The following is a description of a gene set: The synchronization of a circadian rhythm to environmental time cues such as light. studied in species Mus musculus Mouse Gene Set: GOBP_ENTRAINMENT_OF_CIRCADIAN_CLOCK, and this is the list of marker genes: Rbm4, Opn5, Sik1, Rbm4b, Pde6b, Sox14, Trp53, Atoh7, Mta1, Pml, Ppp1cc, Usp2, Cry1, Fbxl21, Phlpp1, Fbxl3, Ppp1cb, Crtc1, Per2, Per3, Cry2, Id2, Bhlhe40, Per1, Ppp1ca, Nr2f6